The following is a description of a gene set: Mouse Gene Set: GOBP_VIRAL_LIFE_CYCLE A set of processes which all viruses follow to ensure survival; includes attachment and entry of the virus particle, decoding of genome information, translation of viral mRNA by host ribosomes, genome replication, and assembly and release of viral particles containing the genome. species: Mus musculus, and this is the list of marker genes: Smpd1, Pkn2 (protein kinase N2), Trim5, Myh9, Tsg101, Hspa8, Slc7a1, Cav2, Oasl1, Tpcn2, Ppid, Banf1, Stom (NCBI Gene Id 227754), Tmem39a, Ddx3x, Tnf, Tmprss11e, Lrrc15, Tmprss11d, Furin, Hsp90ab1, Nectin2, Trim30d, Oas1a, Zfp639, Fkbp6, Atg16l2 (NCBI Gene Id 73683), Vps16, Mndal, Cd209d, Tbc1d20, Larp1, Trim31, Ifi203, Vamp8, Shfl, Isg15, Ifi209, Slamf1, Mphosph8, Ceacam1, Mvb12a, Ifi213, Chmp3, Apoe, Mvb12b, Chmp1b, Ltf, Oas2, Zfyve1, Ccnk, Chmp2a, Lgals1, Tmprss4, AU040320, Zfp809, N4bp1, Ifitm3, Slc3a2, Ifi203-ps, Hacd3, Ifnl3, Clec5a, Nrp1, Oas1f, Trim11, Ifi214, Avpr1b, Rab1a, Ch25h, Trim12a, Clec4g, Tnfrsf14, Trim28, Rsad2, Phb1, Ppib (peptidylprolyl isomerase B), Hmgb1, Smc5, Avp, Rnasel (ribonuclease L (2', 5'-oligoisoadenylate synthetase-dependent)), Mir93 (NCBI Gene Id 723885), Ark2n, Kpna6, Itgav, Arl8b, Fmr1 (NCBI Gene Id 207836), Chmp5, Cd300ld, Cldn6, Ddx56, Rab1b, Ccl5, Cd209c, Ifitm1, Cldn1, Rab43, Tarbp2, Ppih, Dpp4, Chmp7, Npc1, Dag1, Smc6, Top2a, Tmprss2, Agtr1b, Trim25, Top2b, Gbp7, Bsg, Fam111a, Slpi, Vps37b, Trim62 (tripartite motif-containing 62), Usp6nl, Cnot7, Csnk2b, Pik3c3, Vps4a, Slc20a2, Atg5, Notch1, Cldn9, Cd74, Chmp1a, Tmem41b, Chmp2b, Mx2, Uvrag, Eif2ak4 (eukaryotic translation initiation factor 2 alpha kinase 4), Isg20, Rad23a, Hmga2, Eef1a1, Itgb3, Zc3h12a, Ifnb1, Atg16l1, Adarb1 (NCBI Gene Id 76716), Vps18, Cd81, Rnasek, Dicer1, Ist1, Inpp5k, Fbxl2, Oas1g, Pikfyve, Spcs1, Bcl2, Ifih1, Naip5, Vps4b, Morc2b (microrchidia 2B), Trim6, Pcsk5, Ifitm2, Spint1, Chmp1b2 (NCBI Gene Id 74520), Mir24-2, Chmp6, Oas1d (NCBI Gene Id 97256), Lrsam1, Vapa, Ctsb, Ace2, Atg7, Smarcb1, Ifi206, Znfx1, Tpcn1, Mir378a, Stau1, Oas1e, Chmp4c, Eps15 (epidermal growth factor receptor pathway substrate 15), Ifi208, Plscr1, Ddx5, Pcbp1, Nr5a2, Cd300lf, Lamp3 (NCBI Gene Id 239739), Gm11772, Cd4, Axl, P4hb, Ifitm7, Siva1, Trim12c, Nucks1, Pcbp2, Zc3hav1, Oas1b, Xpr1, Siglec1, Mir24-1, Hyal2, Nectin1, Cav1, Aicda, Ythdc2, Oasl2, Oas1h, Pdcd6ip, Morc2a, Jpt2, Insr, Ifitm6, Trim38, Nectin4, Eif2ak2, Pde12, Ddx6, Ppihl (peptidyl prolyl isomerase H like), Agtr1a, Oas3, Trim15, Ddb1, Gpr15, Ppie, Ifi207, Vcp, Bst2, Mavs, Gas6, Ccl8, Trim30b, Pcx, Trim30a, Grk2, Tyro3, Hs3st5, Cd209e, Prkn, Ppia, Chmp4b (NCBI Gene Id 96954), Setdb1, Ilf3, Tasor, Slc38a8, Srpk1, Rab7, Nectin3, Oas1c, Vapb, Tmprss11a, Nedd4, D1Pas1, Icam1, Kpna2, Trim30c, Apobec3, Adar, Srpk2, Prox1